The following is a description of a gene set: species: Homo sapiens The B-MYB proto-oncogene is a transcription factor belonging to the MYB family that is frequently overexpressed or amplified in different types of human malignancies. While it is suspected that B-MYB plays a role in human cancer, there is still no direct evidence of its causative role. Looking for mutations of the B-MYB gene in human cell lines and primary cancer samples, we frequently isolated two nonsynonymous B-MYB polymorphic variants (rs2070235 and rs11556379). Compared to the wild-type protein, the B-MYB isoforms display altered conformation, impaired regulation of target genes and decreased antiapoptotic activity, suggesting that they are hypomorphic variants of the major allele. Importantly, the B-MYB polymorphisms are common; rs2070235 and rs11556379 are found, depending on the ethnic background, in 10-50% of human subjects. We postulated that, if B-MYB activity is important for transformation, the presence of common, hypomorphic variants might modify cancer risk. Indeed, the B-MYB polymorphisms are underrepresented in 419 cancer patients compared to 230 controls (odds ratio 0.53; (95%) confidence interval 0.385-0.755; P=0.001). This data imply that a large fraction of the human population is carrier of B-MYB alleles that might be associated with a reduced risk of developing neoplastic disease. Human Gene Set: SCHWAB_TARGETS_OF_BMYB_POLYMORPHIC_VARIANTS_DN from publication Schwab R, Bussolari R, Corvetta D, Chayka O, Santilli G, Kwok JM, Ferrari-Amorotti G, Tonini GP, Iacoviello L, Bertorelle R, Menin C, Hubank M, Calabretta B, Sala A (PMID 18026132) Genes down-regulated in 293 cells (embryonic kidney) expressing polymorphic variants S427G (SNP ID=rs2070235) or I624M (SNP ID=rs11556379) of BMYB., and this is the list of marker genes: HDAC6, PAFAH1B1, HOXB5, GULP1 (NCBI Gene Id 51454), CDC14A, TAF7L, NEK3, CUL9, NR3C2 (NCBI Gene Id 4306), ELF3, BCL3, VEGFC, CDK13, CAMK2B, EVI5 (ecotropic viral integration site 5), RASSF2